The following is a description of a gene set: studied in species Homo sapiens Any process that stops, prevents, or reduces the frequency, rate or extent of the addition of ubiquitin groups to a protein. Human Gene Set: GOBP_NEGATIVE_REGULATION_OF_PROTEIN_UBIQUITINATION, and this is the list of marker genes: KLHL40, PLAA, ARRB2, CEP63, BEX2, MINAR1, FBXO5, PINX1 (PIN2 (TERF1) interacting telomerase inhibitor 1), PARK7, PRMT3, IVNS1ABP, BAG5 (BAG cochaperone 5), SPRY2 (sprouty RTK signaling antagonist 2), BEX1, ABL1, TNFAIP3, RPS7, CHP1, ARRB1, PRKCE, PRKCG, MARCHF7, BEX4, MARCHF6-DT, RPS3, HSPA1B, TTC36, CDK5, TAF1, GTPBP4, RPL5, SIRT7, UFL1, HSPA1A, VPS28, CAV1, PPIA, UBXN1, DTX3L, USP44, CEP78, BAG2, PARP10, CRY1, MIR101-1, SH3RF2, FYN, RPL11 (ribosomal protein L11), U2AF2, SENP2, SVBP, BEX3 (brain expressed X-linked 3), MAD2L1, HDAC8, CAMLG, PABPN1L (NCBI Gene Id 390748), OGT, PER2, USP4, ADGRB1, N4BP1, GCLC, ATG5, ISG15, RPL23, GNL3L, AKT1 (NCBI Gene Id 207), MIR138-1, MAD2L2, TRIM44, SQSTM1, DNAJA1, WNK1 (WNK lysine deficient protein kinase 1), NXN, TSPO, CDKN2A, GPS2, SPOPL